Given this list of marker genes ST6GAL1, B4GALT5, MGAT4B, B4GALT1, ST8SIA3, MGAT4C, ST3GAL4, MGAT4A, B4GALT4, MGAT5, B4GALT2, B4GALT6, ST8SIA2 (ST8 alpha-N-acetyl-neuraminide alpha-2,8-sialyltransferase 2), B4GALT3, ST8SIA6, here is a description of the gene set: Human Gene Set: REACTOME_N_GLYCAN_ANTENNAE_ELONGATION studied in species Homo sapiens N-Glycan antennae elongation